The following is a description of a gene set: This event has been computationally inferred from an event that has been demonstrated in another species.<p>The inference is based on the homology mapping from PANTHER. Briefly, reactions for which all involved PhysicalEntities (in input, output and catalyst) have a mapped orthologue/paralogue (for complexes at least 75% of components must have a mapping) are inferred to the other species. Reactome Pathway: Choline catabolism part of: Metabolism of amino acids and derivatives studied in species Mus musculus electronically inferred by orthology from the curated human pathway, and this is the list of marker genes: Dmgdh, Slc44a2, Sardh